Given this list of marker genes Otogl, Otog, Dcxr, G6pdx, Dhdh, Nudt5, Rpia, G6pd2, Cbr2, Rbks, Uxs1, Fggy, Pgd, Fkrp, Xylb, here is a description of the gene set: Mouse Gene Set: GOBP_PENTOSE_METABOLIC_PROCESS The chemical reactions and pathways involving a pentose, any monosaccharide with a chain of five carbon atoms in the molecule. species: Mus musculus